Given this list of marker genes CXXC1, IFITM3, PRKAG2, APOB, MCRS1, BCL2L1 (BCL2 like 1), TNRC6B, SLC27A3, IER2 (immediate early response 2), DCAF8, CDK18, USP6NL, ID3, WBP11, STX7, HAGH (NCBI Gene Id 3029), CD27, DGKA (NCBI Gene Id 1606), OGFOD1, RPS25 (NCBI Gene Id 6230), SATB2 (NCBI Gene Id 80104), ASAP1, TFCP2, MAN1B1, OSGEP, COCH, IQCH, ACTR2, B3GNTL1, RPS17P5, ISG20, PLEKHO1, MFNG, PCSK7, WNK1, OR2J2, SMARCA5, CCT6B, ACTR8, MYL6, TAF12, CPSF7, DNMT3B (NCBI Gene Id 1789), RNASET2, MAGEB1, RNF31, PSMC4, MYLK3, HSD17B3, AATF, PGP, TM9SF2, MARK3, RPS6KB1, MYRIP, GPR137B, MOG, OAS2, ZNF688, GRK3, AKR1C3, NUBPL, ATP6V1C1, MAGOH, PPP6R2, ZNF551, LGALS3BP, MX1, UTP20, NELFA, SRGN, KDM4D, SCAP, LRIT1, STEAP4, TRPM1, SIRT5, NACA, HMGN2, RPL35, RMND1, TOM1L1, DDX4, PTPRA, ZNF580, NSUN6, SEMG2 (semenogelin 2), IFI6, CCDC40, ANKRD36BP2, SNRNP35, WASF2, FAM171A1, RPL27A, ID4, DCAF1, IFNGR2, SCML2, ARPC1B, PHC2, PMS2P2, NBR2 (neighbor of BRCA1 lncRNA 2), AEN, SYCP2, SPTAN1, RPS14, TSPAN12, PRKAB1, MCM4, SLC26A4, MAP2K5, STAT4, APPL2, IFIT1, DARS1, PLSCR1, NCAPG2, IFI27, NFYC, MX2, DZANK1, TRA2A, KATNA1, ZNF195, EIF2AK1, LOXL1, VIM, RANGAP1, ADD1, PLSCR2 (NCBI Gene Id 57047), HMGB3P30 (high mobility group box 3 pseudogene 30), PCLAF, MAPRE2, ITGB8, GSTK1, STX17, FBXO7, ISG15, SENP7, CENPB, METAP2, HGS, CALM3, MRPL44, HIVEP3, APOA2, NSD2, SLC25A16, ITGB7, POMZP3, PILRB, SOX14, FAM193B, FEZF2, FDXR (ferredoxin reductase), OTUD3, FKBP4, SEMA4F, RANBP3, TNFAIP6, CYTL1, ZNF222, CR2, REX1BD, TCEA1, OR2W1, EXO5, SNX16, DDB2, SAMD4A, IFI44L, CA8, PIEZO2, MYBBP1A, IFIT3, HIPK2, RSAD2, SEMA3G, TUBB4B, IL4R, RPS18, AXIN1, MRTFA, OAS3, NOD1, RHOH, KMT2D, S100A11, S100A4, CCNI, RNF123, CRYZL1, CCR7, TRIM16, FAM215A, USP18, ADAT1, here is a description of the gene set: Human Gene Set: GSE1925_3H_VS_24H_IFNG_STIM_MACROPHAGE_DN Genes down-regulated in macrophages stimulated by IFNG: 3h versus 24h. studied in species Homo sapiens from publication Hu X, Park-Min KH, Ho HH, Ivashkiv LB (PMID 16148108) IFN-gamma transcriptional responses in control and IFN-gamma primed primary human macrophages